Given this list of marker genes Crebrf, here is a description of the gene set: electronically inferred by orthology from the curated human pathway studied in species Mus musculus Reactome Pathway: CREB3 factors activate genes This event has been computationally inferred from an event that has been demonstrated in another species.<p>The inference is based on the homology mapping from PANTHER. Briefly, reactions for which all involved PhysicalEntities (in input, output and catalyst) have a mapped orthologue/paralogue (for complexes at least 75% of components must have a mapping) are inferred to the other species. part of: Unfolded Protein Response (UPR)